The following is a description of a gene set: from publication McClung CA, Nestler EJ (PMID 14566342) Human Gene Set: MCCLUNG_COCAINE_REWARD_5D Genes up-regulated in the nucleus accumbens (a major reward center in the brain) after 5 days of cocaine treatment. species: Mus musculus DeltaFosB (a truncated form of FosB) and CREB (cAMP response element binding protein) are transcription factors induced in the brain's reward pathways after chronic exposure to drugs of abuse. However, their mechanisms of action and the genes they regulate remain unclear. Using microarray analysis in the nucleus accumbens of inducible transgenic mice, we found that CREB and a dominant-negative CREB have opposite effects on gene expression, as do prolonged expression of DeltaFosB and the activator protein-1 (AP-1) antagonist DeltacJun. However, unlike CREB, short-term and prolonged DeltaFosB induction had opposing effects on gene expression. Gene expression induced by short-term DeltaFosB and by CREB was strikingly similar, and both reduced the rewarding effects of cocaine, whereas prolonged DeltaFosB expression increased drug reward. Gene expression after a short cocaine treatment was more dependent on CREB, whereas gene expression after a longer cocaine treatment became increasingly DeltaFosB dependent. These findings help define the molecular functions of CREB and DeltaFosB and identify clusters of genes that contribute to cocaine addiction., and this is the list of marker genes: JUP, FMNL1, ACTR2, TMEM50B, FBXW7, RNASE2, BAIAP2, VAMP2, BTRC, DNAJB9, CORO2B, NELL2, TOP2A, ADORA2A, MTMR9, ATP1B2, MARK2, STX1B, CACNA2D3, CELF2 (NCBI Gene Id 10659), PDE4B, ELN, SPOCK2, TUBB4A, GAD1, ZNRF1, ITFG1, DLG4, KRT16, POU2F1, GADD45A, WBP11, LENG8, PTPN5, PENK, PALM (NCBI Gene Id 5064), SEC14L1 (SEC14 like lipid binding 1), TBR1, ACTL6B, CD4, CAMK2A, TSPAN7, FSCN1, GRIA4 (glutamate ionotropic receptor AMPA type subunit 4), ZFP64, NECTIN2, SDHC, KCND2, KLF13, H1-10, PTP4A2, SH3GL3, MRM3, GOLGA4, CCK, KIF23, NRGN, ADORA1, ADISSP, PER2, SYP, TM9SF3, UNC93B1, CCN2, STXBP1, ACTN1, NPTN, HPS4, MAPRE3, HSPA5, GRIA1, SOX10, OAZ3, SMARCA2, ST6GALNAC5